The following is a description of a gene set: Keratoacanthoma (KA) is a common benign epithelial tumor that originates from the pilosebaceous glands. In most cases, it is characterized by rapid evolution, followed by spontaneous resolution over 4 to 6 months. KA usually presents as a solitary flesh-coloured nodule with a central keratin plug on the sun-exposed skin of elderly individuals. Human Gene Set: HP_KERATOACANTHOMA Keratoacanthoma studied in species Homo sapiens, and this is the list of marker genes: PSENEN, POGLUT1 (protein O-glucosyltransferase 1), POFUT1, KRT5, ERCC4